Given this list of marker genes Slc5a3, Plekha1, Elavl4, Rlim, Dars1, Xpnpep2, Slc38a10, Calm2, Smyd1, Cdhr1, Kat7, Epas1, Scn7a, Rab4b (NCBI Gene Id 75702), Gpr158, Brdt, Ppfia2, Braf, Sowahc, Stx8, Kcnip2, Nog, Fkbp14, Acvr1b, Ift56, Adipor1, Mapk10, Fga, Neurod4, Zfp78, Sinhcaf (NCBI Gene Id 56306), Epb41l2 (NCBI Gene Id 52582), Krt90, Mon2, Acap2, Hsf3, Rab11b (RAB11B, member RAS oncogene family), Abhd12, Dach2, Thrb, Mcm6, Plagl2, Utp15, Ctxn3, Ptpn9, Gulp1, Gas7, Map6d1, Nptn (NCBI Gene Id 20320), Mapt, Fign, Mpdz, Adgra1, Lrrc4b, Fgf13, Hoxa9, Prkg1 (protein kinase, cGMP-dependent, type I), Rock1, Lamtor1, Inpp5a, Pramel7, Kcnk13, Fezf1, Sptlc2, Cyp2ab1 (NCBI Gene Id 224044), Sec24c, here is a description of the gene set: studied in species Mus musculus Mouse Gene Set: MIR_6350 Genes predicted to be targets of miRBase v22 microRNA mmu_miR_6350 in miRDB v6.0 with MirTarget v4 prediction scores > 80 (high confidence targets). from publication Chen Y, Wang X (PMID 31504780)